Given this list of marker genes ZFAT, LTF, PDE10A (NCBI Gene Id 90632), POPDC2, RBSN, TNRC6A, DPP9, CDH13, PTPN4, GRIA3, UVRAG, TNFRSF10B, SYTL5, HEY1, GRID1, CHL1, PAPPA, TRIM58, GALNT10 (polypeptide N-acetylgalactosaminyltransferase 10), CCRL2, CYP4A11, HS6ST3, PIP5K1B, NEK1, HESX1, CNGB3, FHIT, CCSER1, ERC1, ANKS1B, WWP2, RIT2, ZBBX, NR5A2, XPR1, NEO1, LRP1B, ARNT2, ADCY1, PTPRD, MTDH, COP1, ME1, NFIL3, KCNAB1, NSMCE2, here is a description of the gene set: In all, 85% of Ewing's sarcoma family tumors (ESFT), a neoplasm of unknown histogenesis, express EWS-FLI1 transcription factor gene fusions. To characterize direct target genes avoiding artificial model systems, we cloned genomic DNA from ESFT chromatin precipitating with EWS-FLI1. We now present a comprehensive list of 99 putative transcription factor targets identified, for the first time, by a hypothesis-free approach based on physical interaction. Gene-derived chromatin fragments co-precipitating with EWS-FLI1 were nonrandomly distributed over the human genome and localized predominantly to the upstream region and the first two introns of the genes. At least 20% of putative direct EWS-FLI1 targets were neural genes. One-third of genes recovered showed a significant ESFT-specific expression pattern and were found to be altered upon RNAi-mediated knockdown of EWS-FLI1. Among them, MK-STYX, encoding a MAP kinase phosphatase-like protein, was consistently expressed in ESFT. EWS-FLI1 was found to drive MK-STYX expression by binding to a single ETS binding motif within the first gene intron. MK-STYX serves as precedence for successful recovery of direct EWS-FLI1 targets from the authentic ESFT cellular context, the most relevant system to study oncogenic mechanisms for the discovery of new therapeutic targets in this disease. studied in species Homo sapiens Human Gene Set: SILIGAN_BOUND_BY_EWS_FLT1_FUSION from publication Siligan C, Ban J, Bachmaier R, Spahn L, Kreppel M, Schaefer KL, Poremba C, Aryee DN, Kovar H (PMID 15735734) Genes bound by EWSR1-FLT1 fusion but whose expression did not change in STA-ET-7.2 cells (Ewing's sarcoma) after knockdown of EWSR1-FLT1 by RNAi.